Given this list of marker genes MYCBP, ASXL2, SMC4, TNFRSF8, DUSP5, FOXM1, EVA1B, TRAPPC11, DLG5, GPR171, CTLA4, IRF4, PBK, DTL, RAD51, MAD2L1, THBS4, ZWINT, CBLB, EDEM1, SPC25, H2AX, LCP2, ATP8B4, PHGDH, TNFRSF9, CTH, RBM4 (NCBI Gene Id 5936), GPR183, CCNF, COQ3, ITGA4, SCLY, RFC3, MICAL1, NME7, NETO2, LAMB3, DUSP4, CENPF, DIPK1A, NUP54, HNRNPUL1, AQR, ECT2 (NCBI Gene Id 55710), SHCBP1, CBX5, RUFY2, SIRPG, FNBP1, GALNT2, GFPT2, SPAG5 (NCBI Gene Id 10615), CHEK1, HMGB3P1, NINJ2, SMC2, KPNA2, GRK5, PIMREG (NCBI Gene Id 79996), CPEB1, MCM10, HMGB2, NOC4L, ARG2, METTL8, CDC6, SLC25A32, NAB1, CTR9, BMI1, RASGRP1, PCNA, DNA2, CCR4, PHLDA1, FLT3, ITM2A, CDKN3, HPRT1, PXMP2, DNAJC12, ELAC2, STMN1, IFT74, SMC3, ESPL1, SUOX, FAM30A, DCLRE1A, SLC35B1, IP6K2, BMERB1, HMGB3, DKC1, FHL2, EGFL6, HACD1, HELLS, ADAM19 (ADAM metallopeptidase domain 19), SNRPF, AURKB, KIFC1, P4HA2, POU2AF1, IL16, TOX, TPM4, TMPO, C19orf53, CLIC1, MPST, SFXN1, POGLUT2, BRCA1, MDC1, C1orf216, TNFRSF4, ARHGAP19, RAP1GDS1, DLGAP5 (DLG associated protein 5), WDHD1, KIF22, E2F8, MARCKS, WRAP53, SUPT3H, GPN1, CEP57, CHMP4A, SLC39A14, BBIP1, CKS2, VRK1, MCTP2, RGS3, CDC14B, HSPA14, PTGER4, ZBED2, GINS2, SYT11 (NCBI Gene Id 92303), PTBP3, TXNDC15, BUB3, RPS6KA3, FRMD4B, TRADD, MYL6B, FAM200C, POLD3 (NCBI Gene Id 10714), ZFC3H1, CDC73, ARPC5L, HILPDA (hypoxia inducible lipid droplet associated), CD226, BUB1B, TM2D3, TNC, FANCL, NCR3, F5, CAPN2, COCH, SUPT20H, CHST12, HTATSF1, TRAF3IP3 (NCBI Gene Id 80342), SUGP2, CDC25A, LARP7, CTPS1, TPGS2, NR2F1, PGM1, IL2RB (interleukin 2 receptor subunit beta), KIF23, CDC45, CCNA2, PSMD5, SYNGR3, GGTLC1, POLQ, PPCDC, HPGDS, DPP4, VGLL4, TRIB3, PLS3, GPSM2, EWSR1, FZD6, MRE11, AURKA, GGH, LGALS1, DHFR, AASDHPPT, COPZ2 (NCBI Gene Id 51226), APOBEC3B, here is a description of the gene set: CD25+ regulatory T cells develop in the thymus (nTregs), but may also be generated in the periphery upon stimulation of naive CD4 T cells under appropriate conditions (iTregs). The mechanisms that regulate the generation of peripheral iTregs are largely unknown. We used microarrays to gain insights into the molecular program of extrathymic Treg development. Human Gene Set: GSE24634_TEFF_VS_TCONV_DAY10_IN_CULTURE_UP Genes up-regulated in comparison of untreated CD25+ T effector cells at day 10 versus untreated CD25- T cells at day 10. from publication Prots I, Skapenko A, Lipsky PE, Schulze-Koops H (PMID 21347372) species: Homo sapiens